Given this list of marker genes MAGOH-DT, ROPN1B, LINC00640, MT1M, SERPINA5, RPS15AP6, CD302, ARL13A, ADH5, BBC3, DGCR11, MAIP1, AHSG, LINC02777, SLC38A3, LINC02594, FOXP3, LOXL4, PUDPP1, MT1F, MT1X, ERICH6B, LRG1, LINC02487, MMUT, ETFBKMT, SLC23A1, TMEM187, FAM9A, VTN, RDH11, MT1G, RIDA, PNLIP, CRYZ, LINC01124, SDHAF1, SELENOP, DQX1, ORMDL3, KNG1, CYSLTR2, SPRYD4, FTL, SYCE1, HMGB1P20, CFHR1, SRSF10, UGT2B4, MIR320D1, NONOP2, FTLP3, ANGPTL8, PRKAR2A-AS1, FABP1, AZGP1, WWP1-AS1, SNORC, NDUFA4P1, ENSG00000267260, CYB561D1, RPL7AP50, ATF5, RNU7-12P, TMEM177, IL12A, LINC02897, RN7SL660P, CCDC183, FAM72A, ALB, SERPINA7, PGLYRP2, HRG, F12, NDUFAF2P2, JTB-DT, DGCR6L, IGSF1, SMLR1, GLIPR1L1, LINC02418, SERPINC1, ACOT13, FGB, RBFADN, FGA, SCD, TMEM97, SERPINA1, RBISP4, FADS1, DUSP9, PDF, TMEM150A, FIGNL1, SLC10A1, BAALC-AS2, RPS12P3 (NCBI Gene Id 652246), NLRP14, H3P6, TMED5, ANGPTL3, TMEM161A (NCBI Gene Id 54929), ALDH4A1, FGG, SOWAHB, LINC01767, F7, CBR1, CBX7, MBL2, AQP7, MARCHF6-DT, C8B, ANKRD7, DDO, EXTL3-AS1, INO80E, CYP8B1, TCEAL8, MASP2, ZMYM4-AS1, PTGES3P1, CERS2 (ceramide synthase 2), PEBP1, CLEC4G, ENSG00000270174, LINC00309, GSTZ1, here is a description of the gene set: The gene expression program underlying the specification of human cell types is of fundamental interest. The study authors generated human cell atlases of gene expression and chromatin accessibility in fetal tissues. For gene expression, the study authors applied three-level combinatorial indexing to >110 samples representing 15 organs, ultimately profiling ~4 million single cells. The study authors leveraged the literature and other atlases to identify and annotate hundreds of cell types and subtypes, both within and across tissues. Our analyses focused on organ-specific specializations of broadly distributed cell types (such as blood, endothelial, and epithelial), sites of fetal erythropoiesis (which notably included the adrenal gland), and integration with mouse developmental atlases (such as conserved specification of blood cells). These data represent a rich resource for the exploration of in vivo human gene expression in diverse tissues and cell types. Human Gene Set: DESCARTES_MAIN_FETAL_AFP_ALB_POSITIVE_CELLS Marker genes curated from the annotated cluster as represented in the Descartes Human Gene Expression During Development database. studied in species Homo sapiens from publication Cao J, O'Day DR, Pliner HA, Kingsley PD, Deng M, Daza RM, Zager MA, Aldinger KA, Blecher-Gonen R, Zhang F, Spielmann M, Palis J, Doherty D, Steemers FJ, Glass IA, Trapnell C, Shendure J (PMID 33184181)